Given this list of marker genes NPR2, AMH, TNFAIP6, PTX3, ZNF830, NPPC, BMPR1B, EREG, AKT1, GPR149, YTHDC1, here is a description of the gene set: species: Homo sapiens A reproductive process that is a step in the formation and maturation of an ovum or female gamete from a primordial female germ cell. Human Gene Set: GOBP_MAMMALIAN_OOGENESIS_STAGE